The following is a description of a gene set: Regulated Necrosis Mouse Gene Set: REACTOME_REGULATED_NECROSIS species: Mus musculus, and this is the list of marker genes: Casp8, Ubb, Fasl, Chmp2b, Tnfsf10, Fadd, Ripk3, Tnfrsf10b, Chmp6, Stub1, Bax, Hmgb1, Tradd, Bak1 (BCL2-antagonist/killer 1), Il18, Uba52rt, Gzmb, Traf2, Casp1, Xiap, Chmp7, Flot1, Pdcd6ip, Sdcbp, Ripk1, Cycs, Cdc37, Ube2l3, Uba52, Ogt, Ubc, Mlkl, Il1b, Il1a, Chmp3, Chmp4c, Peli1, Flot2, Itch, Birc3, Cflar, Hsp90aa1, Gsdmd, Prkn, Casp3, Chmp4b, Chmp2a, Gm10053, Casp4, Birc2, Rps27a, Fas, Gsdme, Elane